Given this list of marker genes TPM1 (NCBI Gene Id 7168), SORL1, SSH1 (NCBI Gene Id 54434), SIX1 (NCBI Gene Id 6495), PRKG1, TRIB1, POSTN, MIR503, DDR1, CCL5, PDGFD, BMPR1A (NCBI Gene Id 8035), MSTN, SMO, BCL2, SIX4, XBP1, MIR214, LPAR1, DDR2, AAMP, BIN3, CORO1B, TERT (telomerase reverse transcriptase), FOXO4, GRB10, ANXA1, MIR451A, ITGB3, MIR1298, NRP1, MIR665, SLIT2, ABHD2, HAS2, MIR21, ROCK1, AKIRIN1, MIR15A, SERPINE1, TCP11L2, AIF1 (NCBI Gene Id 9471), MIR26A1, S100A11, MIR20A, PPARD, ADAMTS1, VTN, PLXNA1, NET1, ITGB1BP1, THBS4, MIRLET7B, BMP4, MIR499A, MIR362, TACR1, IGF1, TLR4, MIR135B, MEGF10, PLEKHO1, NR4A3, MIR221, PLAT, MIR223, FGF9, PAK1, NDRG4, DDIT3, IGFBP3, PLAU, MIR638, MIR34A, MIR302C, GNA12, IGFBP5, DOCK7, SEMA6D, NF1, PDGFB, MAP3K7, PDGFRB, MDM2, DOCK4, PARVA, ITGA2, MEF2C, ADIPOQ, MIR424, MIR146A, MIR137, NFE2L2, GSTP1, CRK, MIR448 (microRNA 448), PDGFA, DOCK5, LRP1, MIR140, CCN4, CCN3, MYOCD, MIR182, FAT1, PTPN1, MIR218-1, MDK, ACE, MIR143, here is a description of the gene set: The orderly movement of a muscle cell from one site to another, often during the development of a multicellular organism. Human Gene Set: GOBP_MUSCLE_CELL_MIGRATION species: Homo sapiens